The following is a description of a gene set: studied in species Mus musculus CDK-mediated phosphorylation and removal of Cdc6 Mouse Gene Set: REACTOME_CDK_MEDIATED_PHOSPHORYLATION_AND_REMOVAL_OF_CDC6, and this is the list of marker genes: Ubc, Cdc16 (CDC16 cell division cycle 16), Psmc1, Uba52rt, Anapc10, Adrm1, Psma1, Cdc23, Psma7, Psma5, Cdc27, Ccne1, Psmc3, Psmd2, Psmb6, Psmb4 (proteasome (prosome, macropain) subunit, beta type 4), Psmc6, Psmc5, Ubb, Psmc2, Anapc16, Psmd3, Rps27a, Psmb3, Psmd11, Psmd13, Psmb2, Anapc2, Psmd7, Ccna2, Psmd12, Anapc7, Anapc11, Anapc15, Cdc6, Psmc4, Psmd14, Anapc1, Anapc5, Psmd1, Anapc4 (NCBI Gene Id 67924), Ccne2, Ube2s, Cdc26, Psma2 (NCBI Gene Id 19166), Psmb1, Psma4, Psma3 (proteasome subunit alpha 3), Psma6, Cdk2, Ube2e1, Uba52, Fzr1, Psmb7, Ube2d1, Ccna1, Ube2c, Psmd8, Psmd6, Psmb5